Given this list of marker genes ZFAND5, SHC1, NAPSA, UGCG, CLOCK, REN, DDIT4, ENY2, MCUR1, GPX2, PGRMC2, TPP2, IER2, DLX6, MATN2, KIF3A, DNAAF11, LTA (lymphotoxin alpha), SPOUT1, IRF1 (interferon regulatory factor 1), ITM2B, CCR5, CDS2, CXCL13, HOXB4, SOAT2, ZEB1, ADORA2B, PLK2, WNT7B, ENKD1, HK2, ALCAM, SULT2B1, TGFBI, SARAF, IHH (NCBI Gene Id 50819), TUBB3, TAX1BP1, ANKRD33B, DACH1, IGF1R, SYT2, MSMB (NCBI Gene Id 4477), MYH4, UGDH, CBX6, MSX1, CASP4 (NCBI Gene Id 837), RORC, CHRNB2, LIPE, SRPRA, ALAS2, PIGK, B4GALT6, HIC1, PPP4R2, ITGAE, NPNT, GRIK5 (NCBI Gene Id 2901), SLC10A3, CTSS, SPSB1, NEUROG1, HAL, E2F5, FLNB, EFNB2, IRF8, HASPIN, AK1, CANX, ADAM28, TENM1, VKORC1, CAT, NCF4, BASP1, ROR2, ACP1, DBF4, ENPEP (glutamyl aminopeptidase), PCP4, ZIC2, DCAF12, OSBPL1A, NQO1, STRN4, ABCB9, KCNQ2, TNPO3, SRPRB, ESRP2, SORBS1, CLEC4A, TAF11, TMPRSS2, ZKSCAN1, CLCNKB, GSTM5, BLK, BCAS2, IL12RB1, ITPR2, S100A6, DDX25 (NCBI Gene Id 29118), TNNC1, AASS, GDPD5, CENPE, SYT6, C16orf89, S100A4, DEGS1, CRYGC, MGP, CYTIP, ABCG1, COL6A1, AKR1B1, PHLDA2, SYNPO, PTGS1, HPGD, FANCG, NKX2-2, ACO1, AP1G2, PSIP1, CDHR5, MCRIP1, C2, MMP12, TAF1D, HGSNAT, PRADC1, CCR1 (NCBI Gene Id 1230), CYBC1, SMIM7, CIZ1, RESP18, COL1A1, SLC1A2, G6PC1, MRPL45, PAX6, USP48, CASK, WLS, EIF1B, ATP11A, ANXA1, EFNA5, CAPRIN1, MAP3K1, SLC12A4, ISLR, RNASE1, SLTM, PDX1, ALDH1A1, CAVIN2, PTPN22, KMT5C, CCN3, TRPC4, MCL1, KLF5, SAG, C9, TAF8, ATRAID, KLHL24, UVRAG, TSC2, TMEM41B, CFAP418, HBEGF, RET, UBA5, RPRD1B, INTS9, SEPTIN6, PHLDA1, BHLHE40, NYNRIN, WWTR1, SERPINB2, HDLBP, TSPAN5, RBPJ, FABP5, GBP4, POLDIP3, CCNT1, GAB1, OMD, DYRK1B, here is a description of the gene set: studied in species Homo sapiens from publication Yosef N, Shalek AK, Gaublomme JT, Jin H, Lee Y, Awasthi A, Wu C, Karwacz K, Xiao S, Jorgolli M, Gennert D, Satija R, Shakya A, Lu DY, Trombetta JJ, Pillai MR, Ratcliffe PJ, Coleman ML, Bix M, Tantin D, Park H, Kuchroo VK, Regev A (PMID 23467089) Despite their enormous importance, the molecular circuits that control the differentiation of Th17 cells remain largely unknown. Recent studies have reconstructed regulatory networks in mammalian cells, but have focused on short-term responses and relied on perturbation approaches that cannot be applied to primary T cells. Here, we develop a systematic strategy – combining transcriptional profiling at high temporal resolution, novel computational algorithms, and innovative nanowire-based tools for performing gene perturbations in primary T cells – to derive and experimentally validate a temporal model of the dynamic regulatory network that controls Th17 differentiation. The network is arranged into two self-reinforcing and mutually antagonistic modules that either suppress or promote Th17 differentiation. The two modules contain 12 novel regulators with no previous implication in Th17 differentiation, which may be essential to maintain the appropriate balance of Th17 and other CD4+ T cell subsets. Overall, our study identifies and validates 39 regulatory factors that are embedded within a comprehensive temporal network and identifies novel drug targets and organizational principles for the differentiation of Th17 cells. Genes down-regulated in CD4 T helper cells Th17 treated with TGFB1 and IL6: 10h versus 30h. Human Gene Set: GSE43955_10H_VS_30H_ACT_CD4_TCELL_WITH_TGFB_IL6_DN